Given this list of marker genes Grin2c, Atp1a3, Ptk2b, Tiam1, Grik5, Kalrn, Grin2d, Grin3b, App, Cln3, Mef2c, Cdk5r1, Adrb2 (adrenergic receptor, beta 2), Camk2a, Gria3, Gria2, Gria4, Grik1, Dlg4, Grin2a, Plp1, Grik2, Gria1, Nrxn1, Cpeb4, Grin3a, Grik3, Gm527, Grin2b (glutamate receptor, ionotropic, NMDA2B (epsilon 2)), Grin1, here is a description of the gene set: Mouse Gene Set: GOBP_IONOTROPIC_GLUTAMATE_RECEPTOR_SIGNALING_PATHWAY studied in species Mus musculus The series of molecular signals initiated by glutamate binding to a glutamate receptor on the surface of the target cell, followed by the movement of ions through a channel in the receptor complex, and ending with the regulation of a downstream cellular process, e.g. transcription.